Given this list of marker genes Rarb, Zswim6, Bcl11b, Secisbp2, Fgf8, Htt, Bbs2, Bbs4, Ogdh, Mkks, Foxp2, Mecp2, Gli3, Ascl1 (NCBI Gene Id 17172), Drd2, Inhba, Aldh1a3, Lrrk2, Shank3, Slitrk5, Dlx2 (distal-less homeobox 2), Drd1, Hprt1, Bbs1, Dlx1, Gsx2, Slc7a11, here is a description of the gene set: studied in species Mus musculus Mouse Gene Set: GOBP_SUBPALLIUM_DEVELOPMENT The process whose specific outcome is the progression of the subpallium over time, from its formation to the mature structure. The subpallium is the base region of the telencephalon.